Given this list of marker genes GBP3, FURIN, PIM1, NS, GBP5, CASP1, FNTA, FNTB, GBP1, ACTG1, ACTB, PGGT1B, GBP2, SFN, GBP4, here is a description of the gene set: Reactome Pathway: GBP-mediated host defense part of: Antimicrobial mechanism of IFN-stimulated genes The human Guanylate Binding Proteins (GBPs) constitute a family of dynamin-related GTPase, comprising seven members, GBP1 to GBP7 (Kutsch M & Coers J 2021). GBPs are primarily induced by type II interferon-gamma (IFN-γ) and function as key effectors in cell-autonomous immunity against a wide range of intracellular pathogens, many of which reside in pathogen-containing vacuoles. For example, GBPs protect against intracellular bacterial pathogens such as Listeria monocytogenes, Shigella flexneri, Mycobacterium tuberculosis, and Salmonella enterica serovar Typhimurium, as well as protozoan parasites including Toxoplasma gondii (Fisch D et al., 2019; Santos JC et al., 2020). Upon infection, GBPs are recruited to the surface of pathogen‑containing vacuoles or directly to LPS-rich bacterial membrane surfaces, where they oligomerize into a dense protein coat (Pandita E et al., 2016; Zhu S et al., 2024; Kuhm T et al., 2025). Their assembly can disrupt or remodel membranes or promote caspase 4 (CASP4)-mediated inflammatory cell death.<p>GBPs consists of an N-terminal large GTPase domain (LG) and an elongated helical domain, which can be further divided into a middle domain and a C-terminal GTPase effector domain (GED) (Prakash B et al., 2000). The biochemically best-characterized member is GBP1. Its C-terminal CAAX motif undergoes farnesylation catalyzed by the farnesyltransferase (FNT) complex (Nantais CA et al., 1996; Shydlovskyi S et al., 2017; Sistemich L et al., 2020).<p>GBP1-catalyzed GTP hydrolysis to GMP proceeds in two sequential steps (GTP→GDP→GMP) within the LG domain. GTP binding induces GBP1 dimerization in the cytosol, which promotes hydrolysis of GTP to GDP (Ghosh A et al., 2006; Ince S et al., 2021). Subsequent membrane recruitment is associated with a large-scale rearrangement of the middle domain relative to the LG domain via a hinge region. In addition, the C-terminal GED is released from the middle domain, allowing the farnesyl anchor to insert into the membrane (Weismehl M et al., 2024; Zhu S et al., 2024; Kuhm T et al., 2025). These conformational changes drive GBP1 oligomerization, a prerequisite for its antimicrobial activity ((Ghosh A et al., 2006; Schwemmle M & Staeheli P, 1994; Ince S et al., 2021; Weismehl M et al., 2024). In a subsequent step, the nucleotide is repositioned within the catalytic pocket so that the same catalytic residues promote further hydrolysis of GDP to GMP (Ghosh A et al., 2006; Ince S et al., 2021). In the GMP-bound form, the GBP1 coat is thought to disassemble. The reaction product, GMP, can be further metabolized to uric acid, a potential trigger of NLRP3 inflammasome under certain cellular conditions (Xavier A et al., 2020).<p>Once membrane-bound, GBP1 recruits additional GBP members, namely GBP2, GBP3 and GBP4, to form antimicrobial oligomeric complexes (Santos JC et al., 2020; Valeva SV et al., 2023). GBP2, which is geranylgeranylated at C588 within its CAAX motif, cooperates with GBP1 in localizing to bacterial membranes and assembling GBPs antimicrobial coats (Britzen-Laurent N et al., 2010; Dickinson MS et al., 2023). This multimeric GBP coat compromises microbial membrane integrity and/or facilitates activation of caspase-4 (CASP4), promoting non-canonical inflammasome assembly. Activation of CASP4 leads to pyroptotic cell death and maturation and secretion of inflammatory cytokines interleukin-18 (IL-18) and IL-1β (Santos JC et al., 2020; Wandel MP et al., 2020; Zhu S et al., 2024). GBP1 also inhibits actin-based motility of Shigella flexneri by coating the bacterial surface, thereby blocking IcsA-mediated recruitment of N-WASP and subsequent actin polymerization (Kutsch M et al., 2021). S. flexneri counters this restriction by secreting the E3 ligase IpaH9.8, which ubiquitinates and degrades GBPs (Piro AS et al., 2017). GBP1 activity is regulated by PIM1-mediated phosphorylation at S156, promoting its interaction with 14-3-3σ (SFN), which sequesters GBP1 in the cytosol and prevents membrane association (Fisch D et al., 2023). GTP binding allosterically disrupts this inhibitory interaction (Persico M et al., 2015), allowing GBP1 to resume antimicrobial function.<p>In addition to their antibacterial activities, GBPs mediate antiviral responses, for example against herpesviruses, flaviviruses, and retroviruses. In particular, GBP1 restricts the nuclear delivery of DNA viruses such as Kaposi’s sarcoma associated herpesvirus (KSHV) (Zou Z et al., 2017). This may occur through binding and sequestering monomeric G-actin, thereby reducing the pool of polymerization-competent actin, remodeling the actin cytoskeleton, and disrupting actin-dependent intracellular trafficking (Ostler N et al., 2014). In addition, GBP2 and GBP5 inhibit the infectivity of a broad range of enveloped RNA viruses, including human immunodeficiency virus type 1 (HIV-1), Zika virus, measles virus, influenza A virus, and severe acute respiratory syndrome coronavirus 2 (SARS-CoV-2) (Braun E et al., 2019; Mesner D et al., 2023). Both proteins interact with the host proprotein convertase furin (PCSK3), binding to its C-terminal cytoplasmic tail and inhibiting the proteolytic cleavage of viral envelope glycoproteins, such as the HIV-1 envelope glycoprotein gp160 and the SARS-CoV-2 spike glycoprotein (Braun E et al., 2019; Cui W et al., 2021). This inhibition disrupts glycoprotein maturation, intracellular trafficking, and incorporation into nascent virions, thereby reducing viral infectivity (Braun E et al., 2019; Cui W et al., 2021; Mesner D et al., 2023). GBP2 and GBP5 may also restrict viral infectivity by altering trafficking and N-linked glycosylation of viral glycoproteins independently of furin (Krapp C et al., 2016; Cui W et al., 2021; Veler H et al., 2024; reviewed by Sauter D & Kirchhoff F 2024).<br><br><br> studied in species Homo sapiens